The following is a description of a gene set: Genes up-regulated in HeLa cells (cervical carcinoma) 32 h after infection with adenovirus Ad12. The infection of human cells by adenoviruses leads to a gradual reduction in the activity of host cell functions while viral gene expression progresses in a regulated way. We used the DNA microarray technique to determine the transcriptional activity profiles of cellular genes upon infection with adenovirus type 12 (Ad12). The microarray data were validated by quantitative real-time PCR for genes which showed significant alterations after Ad12 infection. At 12 h postinfection, there is a striking up-regulation between 10- and 30-fold in the expression of the G1P2, IFIT1, and IFIT2 cellular immune response genes compared to mock-infected cells. At later stages of infection, when the majority of regulated cellular genes has been turned down, a limited number of cellular genes exhibit increased activities by factors of 3 or less. These genes belong to the signal transduction or transcriptional regulator classes or are active in protein degradation, like ANPEP, an aminopeptidase. The SCD and CYP2S1 genes function in lipid metabolism. The eucaryotic translation initiation factor 4 is up-regulated, and one of the major histocompatibility complex genes is diminished in activity. For two of the genes, one up-regulated (CTSF gene) and one down-regulated (CYR61 gene), alterations in gene activity were confirmed at the protein level by Western blotting experiments. Increased genetic activity of cellular genes late in adenovirus infection has not been reported previously and demonstrates that Ad12 has a sustained control of host cell gene expression well into the late phase of infection. from publication Dorn A, Zhao H, Granberg F, Hösel M, Webb D, Svensson C, Pettersson U, Doerfler W (PMID 15681441) species: Homo sapiens Human Gene Set: DORN_ADENOVIRUS_INFECTION_32HR_UP, and this is the list of marker genes: MYC, ATF4, ELF3, BACE2, PDE2A, RASL12, TOP2A, ANPEP, H2BC12, TSC22D3 (TSC22 domain family member 3), IFIT2